Given this list of marker genes Tgfb1i1, Slit1 (slit guidance ligand 1), Igfals, Rtn4rl1, Myo9b, Slit2, Lgr4, Slit3, Rtn4r, here is a description of the gene set: Mouse Gene Set: GOMF_ROUNDABOUT_BINDING studied in species Mus musculus Binding to Roundabout (ROBO) receptor, a transmembrane receptor.